The following is a description of a gene set: species: Mus musculus Mouse Gene Set: GOBP_NEGATIVE_REGULATION_OF_NUCLEOTIDE_BIOSYNTHETIC_PROCESS Any process that stops, prevents, or reduces the frequency, rate or extent of the chemical reactions and pathways resulting in the formation of nucleotides., and this is the list of marker genes: Parp1, Entpd1, Atp5if1, Pid1, Rd3